The following is a description of a gene set: Any process that activates or increases the frequency, rate or extent of inhibitory postsynaptic potential (IPSP). IPSP is a temporary decrease in postsynaptic membrane potential due to the flow of negatively charged ions into the postsynaptic cell. The flow of ions that causes an IPSP is an inhibitory postsynaptic current (IPSC) and makes it more difficult for the neuron to fire an action potential. Mouse Gene Set: GOBP_POSITIVE_REGULATION_OF_INHIBITORY_POSTSYNAPTIC_POTENTIAL studied in species Mus musculus, and this is the list of marker genes: Rims2, Ntsr1, Nlgn3, Unc13b, Abat, Grin2a, Igsf9b, Grin2b, Nlgn2, Rims1